The following is a description of a gene set: Molybdenum cofactor biosynthesis species: Homo sapiens Human Gene Set: REACTOME_MOLYBDENUM_COFACTOR_BIOSYNTHESIS, and this is the list of marker genes: MOCS3, NFS1, MOCOS, GPHN, MOCS1, MOCS2